Given this list of marker genes LIME1, GZMM, SIRPG, ABLIM1, APPL2, PRMT2, PRKCQ, YES1, PRKCZ, PRKCH, KAT6B, CD3G, FLT3LG, SLC25A38, RORA, IL21R, CD247, ERG28, PIK3IP1, ZNF512B, NELL2, AMMECR1, JADE2, ZNF506, DEXI, CD96, LCK, LTBP4, GYPC, PRKCA, DNAJB1, CD5, ZNHIT6, LIG1, MSH2, FAM162A, TBC1D4, KIF21B, MAL, TNIK, DNAJC9, PDCD4-AS1, PASK, BACH2, CD3E, HMGN1, GALNT12 (polypeptide N-acetylgalactosaminyltransferase 12), CD3D, TRMT11, GPRASP1, DOCK9, ZAP70, ZNF529, ENOSF1, EPHX2, QTRT1 (queuine tRNA-ribosyltransferase catalytic subunit 1), TRAC, ECHDC2, TRIB2, CD28, IL32, RETREG1, PLCG1, DENND2D, SYNRG, PTPRCAP, UBASH3A, AIP (NCBI Gene Id 9049), SPOCK2, ALDOC (NCBI Gene Id 230), CD69, BAG2, NAA40, S1PR1, ZMYND11, RNF144A, UNG, NIPAL3 (NCBI Gene Id 57185), ZBTB25, PDCD4, ADNP2, BEX3, KDM3A, LTBP3, CD27, CD2, CLUHP3, SMYD3, FCMR, LY9, KLHL20, ADGRL1, PRAF2, FANCG, ASXL1, ITK, MPRIP, CDC25B, TPD52, TXK, BCL11B, NR3C2, CCDC25, CCND2, KBTBD4, MLLT3, SH3YL1, CDR2, TFDP2 (NCBI Gene Id 7029), TMEM14A, FAM169A, INPP4B, LRRN3, SATB1, LEF1, NCK2, GCN1, EVL, MDN1, SMPD1, IPP, TMEM63A, MGAT4A, HMCES, ITGA6, RAB33A, PMS2P3, LBH, BIN1, GPR18, LTB, TATDN2, ATP6V0E2, GOLGA8B, TRBC1, AKTIP, PLEKHB1, OXCT1, BCAS4, ITPR3, CBLB, LPIN1, PTCD3, CLK1, ABHD14A (abhydrolase domain containing 14A), BNIP3, EEIG1, MPHOSPH9, RNASEH1, PILRB, SNRPD2, PVRIG, TSPYL4, DPH5, SESN1 (sestrin 1), RASA2, GPX7, BCL2, LDLRAP1, LRIG1, NOSIP, SIDT1, ZSCAN18, ENO2, SUPT3H, DGKA (NCBI Gene Id 1606), PKIA, MAGED1, PJA1, CD7 (CD7 molecule), MOAP1, MLLT11, TMEM204, SKAP1, HMOX2, TRAF5, HSD17B8, SH2D1A, ZNF276, MYLIP, UBIAD1, LRBA, GCFC2, SLC38A1, ATP2A3, COX11, DPP4, CCSER2, UNC119B, GRAP2, CEP68, DDHD2, NUCB2, CLEC2D, PBXIP1, LINC00623, SYNE2, CD6, here is a description of the gene set: Human Gene Set: GSE22886_NAIVE_TCELL_VS_MONOCYTE_UP species: Homo sapiens Immune cell-specific expression is one indication of the importance of a gene's role in the immune response. In order to identify such patterns, we set out to broadly profile gene expression in a variety of immune cells. from publication Abbas AR, Baldwin D, Ma Y, Ouyang W, Gurney A, Martin F, Fong S, van Lookeren Campagne M, Godowski P, Williams PM, Chan AC, Clark HF (PMID 15789058) Genes up-regulated in comparison of naive CD4 CD8 T cells versus monocytes cultured for 0 days.